The following is a description of a gene set: Mouse Gene Set: MIR_374C_3P Genes predicted to be targets of miRBase v22 microRNA mmu_miR_374c_3p in miRDB v6.0 with MirTarget v4 prediction scores > 80 (high confidence targets). species: Mus musculus from publication Chen Y, Wang X (PMID 31504780), and this is the list of marker genes: Plaat3, Styk1, Pld5, Perp, 1700008P02Rik, Hdlbp, Naa15, Ergic2, Cdkn1b, Mindy3, Lix1l, Erlin1, Ripor2, Sult1b1, Nr4a3, Creb5, Rdh7, Lrrc28, Mindy2, Vgf, Tslp, Smcr8, C87436, Nudcd1, Matn3, Zbtb21, Prpf31, Ccnd2, Nlgn1, Sox3, Hpcal4 (NCBI Gene Id 215010), Mier1, Ola1, Brwd1, Pmp22, Clca3a1, Tcfl5, Rhod, Wtap, Msl2, Sptbn1 (spectrin beta, non-erythrocytic 1), Trim6, Tmprss11a, Havcr1, Magi3, Yy1, Ldah, Ogfod1, Cpeb3, Lrrk1, Hmgb2, Scfd1, Far1, AI593442, Mtap, Clec2l, Slc20a1, Rprd1b, Tcaim, Fut9, Trim32, Pde7a, Kcnmb2, Taf4, Gm14092, Cbr4, Taf11, Lgals8